The following is a description of a gene set: Any process that increases the internal pH of a cell, measured by the concentration of the hydrogen ion. Mouse Gene Set: GOBP_INTRACELLULAR_PH_ELEVATION studied in species Mus musculus, and this is the list of marker genes: Cln3, Slc45a2, Cftr, Slc26a3, Slc26a6, Tmem175, Oca2